Given this list of marker genes Adam8, Lypd3, Krt6a, Bnc1, Tfap2a, Pkp1, Col17a1, Gpr87, Krt5, Ppbp, Tiam1, Trp63, here is a description of the gene set: species: Mus musculus Cluster A: genes up-regulated in primary lung tumors driven by KRAS activation and loss of STK11; also up-regulated in human squamous cell carcinoma (SCC) vs adenocarcinoma subtype of NSCLC (non-small cell lung cancer). from publication Ji H, Ramsey MR, Hayes DN, Fan C, McNamara K, Kozlowski P, Torrice C, Wu MC, Shimamura T, Perera SA, Liang MC, Cai D, Naumov GN, Bao L, Contreras CM, Li D, Chen L, Krishnamurthy J, Koivunen J, Chirieac LR, Padera RF, Bronson RT, Lindeman NI, Christiani DC, Lin X, Shapiro GI, Jänne PA, Johnson BE, Meyerson M, Kwiatkowski DJ, Castrillon DH, Bardeesy N, Sharpless NE, Wong KK (PMID 17676035) Germline mutation in serine/threonine kinase 11 (STK11, also called LKB1) results in Peutz-Jeghers syndrome, characterized by intestinal hamartomas and increased incidence of epithelial cancers. Although uncommon in most sporadic cancers, inactivating somatic mutations of LKB1 have been reported in primary human lung adenocarcinomas and derivative cell lines. Here we used a somatically activatable mutant Kras-driven model of mouse lung cancer to compare the role of Lkb1 to other tumour suppressors in lung cancer. Although Kras mutation cooperated with loss of p53 or Ink4a/Arf (also known as Cdkn2a) in this system, the strongest cooperation was seen with homozygous inactivation of Lkb1. Lkb1-deficient tumours demonstrated shorter latency, an expanded histological spectrum (adeno-, squamous and large-cell carcinoma) and more frequent metastasis compared to tumours lacking p53 or Ink4a/Arf. Pulmonary tumorigenesis was also accelerated by hemizygous inactivation of Lkb1. Consistent with these findings, inactivation of LKB1 was found in 34% and 19% of 144 analysed human lung adenocarcinomas and squamous cell carcinomas, respectively. Expression profiling in human lung cancer cell lines and mouse lung tumours identified a variety of metastasis-promoting genes, such as NEDD9, VEGFC and CD24, as targets of LKB1 repression in lung cancer. These studies establish LKB1 as a critical barrier to pulmonary tumorigenesis, controlling initiation, differentiation and metastasis. Mouse Gene Set: JI_CARCINOGENESIS_BY_KRAS_AND_STK11_UP